Given this list of marker genes NELFB, ELOA, SUPT5H (NCBI Gene Id 6829), POLR2K, CDK7, POLR2C, POLR2F, ERCC3, CTDP1, NCBP2, CCNH, GTF2H1 (NCBI Gene Id 2965), POLR2E, NELFE, ELL, ELOC, GTF2H2, POLR2J, GTF2H4, NELFA, ERCC2, ELOB (NCBI Gene Id 91153), POLR2D, SUPT16H, POLR2G, MNAT1, POLR2H, POLR2L, ELOA2, GTF2F2, TCEA1, CDK9, NCBP1, GTF2F1 (general transcription factor IIF subunit 1), POLR2B, POLR2A, SUPT4H1, GTF2H5, CCNT1, NELFCD, SSRP1, GTF2H3, POLR2I, here is a description of the gene set: Human Gene Set: REACTOME_HIV_TRANSCRIPTION_ELONGATION HIV Transcription Elongation studied in species Homo sapiens